The following is a description of a gene set: species: Homo sapiens Any process that activates or increases the frequency, rate or extent of focal adhesion assembly, the establishment and maturation of focal adhesions. Human Gene Set: GOBP_POSITIVE_REGULATION_OF_FOCAL_ADHESION_ASSEMBLY, and this is the list of marker genes: PPM1F, POLDIP2, SFRP1, MYOC, ABL1, WNT4, EPB41L5, MAP4K4, TEK, ITGB1BP1, SMAD3, HRG, CFL1, TSC1, RAC1 (NCBI Gene Id 5879), LIMS1, FERMT2, THY1, VEGFA, PTPRJ, COL16A1, KDR, NRP1, S100A10 (S100 calcium binding protein A10), SDC4, ROCK1 (Rho associated coiled-coil containing protein kinase 1)